The following is a description of a gene set: studied in species Mus musculus from publication Yao MW, Lim H, Schust DJ, Choe SE, Farago A, Ding Y, Michaud S, Church GM, Maas RL (PMID 12554760) Human infertility and recurrent pregnancy loss caused by implantation defects are poorly understood. Hoxa-10-deficient female mice have severe infertility and recurrent pregnancy loss due to defective uterine implantation. Gene expression profiling experiments reveal that Hoxa-10 is an important regulator of two critical events in implantation: stromal cell proliferation and local immunosuppression. At the time of implantation, Hoxa-10 mediates the progesterone-stimulated proliferation of uterine stromal cells. Hoxa-10 mutants express a stromal cell proliferation defect that is accompanied by quantitative or spatial alterations in the expression of two cyclin-dependent kinase inhibitor genes, p57 and p15. Hoxa-10 deficiency also leads to a severe local immunological disturbance, characterized by a polyclonal proliferation of T cells, that occurs in place of the normal progesterone-mediated immunosuppression in the periimplantation uterus. Mouse Gene Set: YAO_TEMPORAL_RESPONSE_TO_PROGESTERONE_CLUSTER_7 Genes co-regulated in uterus during a time course response to progesterone: SOM cluster 7., and this is the list of marker genes: Dda1, Atp1a1, Eif3j1, Cldn3 (claudin 3), Gnb1, Zfpm1, Sar1b, Cnga2, Ppp1r15b, Fam136a, Tapbp, Anxa3, Arhgap35, Brd2, Psma2, Eif4a-ps4, Kif5b, Cherp, Leprot (NCBI Gene Id 230514), Arl8b, Mrpl43, Wsb2, Mterf3, Ppm1g, Tm2d2, Eif2s1, Cdc34b, Ncdn, Itgb1bp1, Jagn1, Hras, Maip1, Sult1a1, Rab7, Cnn2, Pgls, Ankrd40, Midn, Sod2, Ddx3x, Ubqln2, Amotl2, Ramp1, Snai1, Lrp8 (NCBI Gene Id 16975), Mt1, Zfp281, Cops3, Scamp2, Fzd2, Hnrnpa2b1, Hspa4, Brix1, Sertad1, Cdv3, Emc8, Mgat2, Tpd52l1, Cbx4, Bcat2, Rreb1, Ptk2, Rasip1, Crip1, Mrpl17, Foxa2, Ganab, Mrps26, Etf1, Slc25a48, Rem1, Anp32b, Hnrnpc